The following is a description of a gene set: studied in species Homo sapiens Human Gene Set: GOBP_VASCULAR_ENDOTHELIAL_GROWTH_FACTOR_RECEPTOR_2_SIGNALING_PATHWAY The series of molecular signals initiated by a ligand binding to a vascular endothelial growth factor receptor-2 (VEGFR-2) on the surface of a target cell, and ending with the regulation of a downstream cellular process, e.g. transcription., and this is the list of marker genes: KDR, DAB2IP, CLEC14A, PDCD6, VEGFA, SLC31A1